Given this list of marker genes UGT1A10, CYP11B2, CYP11B1 (NCBI Gene Id 1584), CYP21A2, HSD11B2, HSD11B1, AKR1C1, AKR1C2, UGT2B7, SRD5A2, AKR1D1, SRD5A1, AKR1C3, AKR1C4, here is a description of the gene set: Mineralocorticoid biosynthesis Human Gene Set: WP_MINERALOCORTICOID_BIOSYNTHESIS species: Homo sapiens